The following is a description of a gene set: Mouse Gene Set: TABULA_MURIS_SENIS_MARROW_GRANULOCYTOPOIETIC_CELL_AGEING species: Mus musculus from publication Tabula Muris Consortium (PMID 32669714), and this is the list of marker genes: H2-Eb1, Ccdc34, Arhgdib, Smc2, Nfe2, Ngp, Mcemp1, Hcst, Ifitm6 (NCBI Gene Id 213002), Nusap1, Fcer1g, Ap3s1, Tspo, AA467197, Cdca3, Alas2, H2ax, Lcn2, Cd63, Anxa2, Arf5, Lyz2, Slpi, Cyba, Cks2, Serpinb1a, Ube2c, Ly6c2, Tyrobp, Clec4a2, Ncf4, Apoe, Ms4a3, S100a11 (NCBI Gene Id 30048), Arl6ip1, Tmed3, Emp3, Malat1, S100a8, Arrb2, Cdk1, Cd177, Hp, Bsg, Cebpe, Fth1, Prdx5, Tuba4a, Ifitm3, Ltb4r1 (NCBI Gene Id 16995), Vamp8, Trem3, Orm1, Gpx1, S100a6, Camp, Hmbs, Car2, Ftl1, Fcnb, S100a9 (S100 calcium binding protein A9 (calgranulin B)), Grina, Blvrb, Clec12a (NCBI Gene Id 232413), Cpne3, Dstn, Msrb1, Lyz1, Retnlg, Cdkn2d, Prtn3 (proteinase 3), Spc25, Cd52, Rgcc, Ltf, Birc5, Lgals3, Lamtor4, 1810037I17Rik, Atp5if1, Lrg1 (leucine-rich alpha-2-glycoprotein 1), Cd9, Alox5ap, Gpsm3, Cebpd, Prdx2, Pglyrp1, Chil3, Ifitm2, Wfdc21, H2ac23, Gpx4, Glrx5, Cdca8, Cybb, Fxyd5, Ube2l6, Elane, Gsr, Reep5, Gypa, Anxa1, Spi1 (Spi-1 proto-oncogene), H2-Aa, Tuba1c, Pgp, Jchain